Given this list of marker genes HPN, HGF, MET, SPINT1, SPINT2, HGFAC, here is a description of the gene set: species: Homo sapiens Human Gene Set: REACTOME_MET_RECEPTOR_ACTIVATION MET Receptor Activation